The following is a description of a gene set: Human Gene Set: RBM15_TARGET_GENES Genes containing one or more binding sites for (RBM15) in their promoter regions (TSS -1000,+100 bp) as identified by GTRD version 20.06 ChIP-seq harmonization. species: Homo sapiens from publication Yevshin I, Sharipov R, Kolmykov S, Kondrakhin Y, Kolpakov F (PMID 30445619), and this is the list of marker genes: H2AC20, CARS2 (NCBI Gene Id 79587), TUBB6, TENT4B, LINC01686 (long intergenic non-protein coding RNA 1686), SNORA16A, H2AC7 (NCBI Gene Id 3013), ATF5, MIR17HG, ADAD1, GSE1, RMI2, MAN1C1, VIM, CCP110, SUMO2, RAD17, RPL35, ZPBP2, PHF3, AHCYP7, DNLZ, RPS2, KDM6A, MYLIP, ZNF124, GTPBP1, SNORA78, GIPC1, MFSD11, H2BC21, DBNDD1, TPRN, ADGRL1, PRPSAP2, TP53BP2, H2BC17, ADARB1, H1-4, KCNC1, TRIM27, WIPI2, SLC25A6, ANXA5, DDX5, PGAP6, PTP4A1P6, MCL1, NUP62, PTP4A1, FOS, OSTF1, SNHG12, OR2B8P, NHLRC3, MEPCE, SNHG9, NUBP2, MIR4310, ABHD13, IQGAP1, CTNNB1, INSL3, FAHD1, ABL2, DPY19L1, HECTD2 (HECT domain E3 ubiquitin protein ligase 2), H2BC11, ARPC5L, COX11, SSR4P1, XBP1 (X-box binding protein 1), DUSP28, DLEU2, PRDX1, ATOX1, H2BC12, EIF4A2, CXCL12, ROR2, FBXO34-AS1, UBC, MAP4K3, MIR1470, BOLA1, AJUBA, MRPL40, CST6, HSP90AA1, DDX19B, HUNK, ENSG00000263080, WTAP, HNRNPAB, CD248, RIPOR1, PRCD, HAS3, CPSF6, SRSF2, H2BC7, H3-3B, SPSB3, NLRC5, IL4I1, FAM131B, TMEM139, SOHLH2, ICMT, VAV3, HIRA, ACTB, SON, ATF3, LIG4, LINC01719, GPR137, MIR3190, ZCWPW1, NALT1, IPPK, ING1, KLF6, MIR3143, ANKRD17-DT, TICAM2-AS1 (TICAM2 antisense RNA 1), RPS15, TCF3, TRAK2, C15orf48, PRDM16-DT, CSNK1D, MIR5188, TLE3, NSFL1C, RNF148, RFWD3, TPTEP1, CDC25C, PXMP2, BAMBI, FBXO34 (NCBI Gene Id 55030), PROSER1, WNT2B, VSNL1, TICAM2 (TIR domain containing adaptor molecule 2), NMD3, LRRC8D-DT, B3GAT2, ZCCHC2, DAGLA, MDGA1, PRKD3, SNORD43, ANKMY1, PPP1R26, ST7-OT4 (ST7 overlapping transcript 4), SCAMP4 (secretory carrier membrane protein 4), STKLD1, PTCHD3P3, AKAP7, LRRC8D, ESPN, RPL3, PCBP1-AS1, ENSG00000229797, KLF13, NCOA1, CEP95, HNRNPH1, DNAAF11, POLE (DNA polymerase epsilon, catalytic subunit), SERPINI2, CCDC162P, LHFPL2, FNDC3B, ANP32BP3, RNU4-2, SNHG7, ZNF204P, HIPK1, FAM78A, ACTG1, CLCN7, IGF2BP3, PPP1R15A, TPI1, PTBP1, DEUP1, TMPOP2, SLC9A1, VIM-AS1, SRPRB, PSME4, ANKRD17, CHD7, NMRK1, GUSBP5